Given this list of marker genes PNPLA6, ENPP6 (ectonucleotide pyrophosphatase/phosphodiesterase 6), GDPD3 (NCBI Gene Id 79153), PNPLA7, GDPD5, GDE1, GDPD1, here is a description of the gene set: studied in species Homo sapiens Reactions grouped in this pathway because of their shared chemistry - the hydrolysis of various phosphatidyl inositols and related phospholipids. They differ, however, in the tissues in which they occur and in their likely physiological roles. The activities of PNPLA6 and GDPD5 annotated here, for example, are especially prominent in kidney cells where the choline they generate plays a role in protecting cells from osmotic stress. Expression of others may be correlated with specific developmental events. Reactome Pathway: Glycerophospholipid catabolism part of: PI Metabolism